The following is a description of a gene set: Reactome Pathway: Keratan sulfate biosynthesis studied in species Homo sapiens Three keratan sulfate polymers have been found (KS-I, KS-II, KS-III) bound to core proteins. KS-I is the best characterised keratan sulfate. It is 10 times more abundant in cornea than cartilage. KS-I is elongated by the alternate additions of galactose (Gal) and N-acetylglucosamine (GlcNAc), mediated by glycosyltransferases. Elongation is often terminated by the addition of a single N-acetylneuraminic acid (sialyl) or a fucose residue. KS-I is also sulfated on many Gal and GlcNAc residues by at least two sulfotransferases. These reactions are running in parallel which we cannot represent in the diagram. The intermediate reaction products shown are therefore only for demonstration purposes. part of: Keratan sulfate/keratin metabolism, and this is the list of marker genes: ST3GAL1, B4GALT4, SLC35D2, KERA, LUM, B3GNT2, B4GALT1, B4GAT1, ST3GAL6, B4GALT3 (beta-1,4-galactosyltransferase 3), OMD, CHST5 (NCBI Gene Id 82922), ST3GAL4, ST3GAL2, PRELP, CHST3, OGN (NCBI Gene Id 4969), CHST1, B4GALT2, B3GNT3, B4GALT6, B3GNT7, CHST6, CHST2, B4GALT5, ACAN, FMOD, ST3GAL3, B3GNT4